The following is a description of a gene set: part of: ESR-mediated signaling Reactome Pathway: Estrogen-dependent gene expression studied in species Homo sapiens Estrogens mediate their transcriptional effects through interaction with the estrogen receptors, ESR1 (also known as ER alpha) and ESR2 (ER beta). ESR1 and ESR2 share overlapping but distinct functions, with ESR1 playing the primary role in transcriptional activation in most cell types in the target gene promoter, or indirectly through interaction with another DNA-binding protein such as RUNX1, SP1, AP1 or NF-kappa beta. Binding of estrogen receptors to the DNA promotes the assembly of higher order transcriptional complexes containing methyltransferases, histone acetyltransferases and other transcriptional activators, which promote transcription by establishing active chromatin marks and by recruiting general transcription factors and RNA polymerase II. ESR1- and estrogen-dependent recruitment of up to hundreds of coregulators has been demonstrated by varied co-immunoprecipitation and proteomic approaches. In some circumstances, ligand-bound receptors can also promote the assembly of a repression complex at a target gene, and in some cases, heterodimers of ESR1 and ESR2 serve as repressors of ESR1-mediated target gene activation. Phosphorylation of the estrogen receptor also modulates its activity, and provides cross-talk between nuclear estrogen-dependent signaling and non-genomic estrogen signaling from the plasma membrane <br><br>A number of recent genome wide studies highlight the breadth of the transcriptional response to estrogen. The number of predicted estrogen-dependent target genes ranges from a couple of hundred (based on microarray studies) to upwards of 10000, based on ChIP-chip or ChIP-seq. Many of these predicted sites may not represent transcriptionally productive binding events, however. A study examining ESR1 binding by ChIP-seq in 20 primary breast cancers identified a core of 484 ESR-binding events that were conserved in at least 75% of ER+ tumors, which may represent a more realistic estimate. These studies also highlight the long-range effect of estrogen receptor-binding, with distal enhancer or promoter elements regulating the expression of many target genes, often through looping or other higher order chromatin structures. Transcription from a number of estrogen-responsive target genes also appears to be primed by the binding of pioneering transcription factors such as FOXA1, GATA3, PBX1 among others. These factors bind to heterochromatin by virtue of their winged helix domains and promote chromatin opening, allowing subsequent recruitment of other transcription factors, and this is the list of marker genes: YY1, POU2F1, CARM1, FOXA1, FOSB, SMC3, TFF1 (NCBI Gene Id 7031), GATA3, AGO2, H2BC1, HDAC1, MIR26A1, POLR2L, KPNA2, KANK1, H2BC17, JUN, NR5A2, TBP, NRIP1, CCND1, H2BC14, AGO3, PTGES3, H2BC12L, AGO4, H2BC11, H2AZ2, MIR26B, TNRC6B, POLR2K, H2BC26, HSP90AB1, H3C1, GTF2A1, POLR2J, H4C1, POLR2I, CXXC5, CCNT1, FKBP4, H2BC21, BCL2, H2AC20 (H2A clustered histone 20), ERBB4 (NCBI Gene Id 2066), AGO1, MED1, CBFB, USF2, PGR, GTF2F2 (general transcription factor IIF subunit 2), USF1 (upstream transcription factor 1), H3-3A, STAG1, EBAG9, H2BC4, FOS, POLR2A, H2AC18, CREBBP, EP300, POLR2C, MOV10, ATF2, MYB, H2AC4, H2BC12, JUND (NCBI Gene Id 3727), NCOA1, POLR2F, H2AJ, TNRC6C, H2BC13, H2BC15, H2AC14, GTF2A2, PRMT1, CITED1, SP1, H2AC7, KDM4B, H2BC9, CTSD, CDK9, GREB1, KDM1A, H2AB1, CHD1, H2BC3, POLR2D, TLE3, H3C15 (H3 clustered histone 15), POLR2H, KAT5 (lysine acetyltransferase 5), POLR2G, KAT2B, NCOA2, GTF2F1, SMC1A, MIR26A2, H2AX, POLR2B, DDX5, RUNX1, STAG2, MYC, TNRC6A, NCOA3, POLR2E, ESR1, TGFA, GPAM, TFF3, KCTD6, CXCL12 (NCBI Gene Id 6387), AXIN1, H2AC6, H2BC5, HSP90AA1, ZNF217 (zinc finger protein 217), RAD21